Given this list of marker genes Dnm1l, Nlgn1, Cacna1d, Syt1, Slc4a8, Bcl2l1, here is a description of the gene set: Any process that activates or increases the frequency, rate or extent of synaptic vesicle exocytosis. Mouse Gene Set: GOBP_POSITIVE_REGULATION_OF_SYNAPTIC_VESICLE_EXOCYTOSIS studied in species Mus musculus